The following is a description of a gene set: Human Gene Set: GOBP_POSITIVE_REGULATION_OF_CONNECTIVE_TISSUE_REPLACEMENT Any process that activates or increases the frequency, rate or extent of connective tissue replacement. species: Homo sapiens, and this is the list of marker genes: MIR214, MIR15B, MIR34C, MIR34A, PPP3CA (protein phosphatase 3 catalytic subunit alpha), ROCK1, MIR199A1, ROCK2, MIR195, MIR16-1, MIR34B, MIR17